Given this list of marker genes DAGLA, CD40, UCN3, CRH, BIN1, MAP1B, UCN, CRHBP, here is a description of the gene set: Non-terminal inflated portion of the axon, containing the specialized apparatus necessary to release neurotransmitters. species: Homo sapiens Human Gene Set: GOCC_VARICOSITY